The following is a description of a gene set: Genes predicted to be targets of miRBase v22 microRNA mmu_miR_7016_3p in miRDB v6.0 with MirTarget v4 prediction scores > 80 (high confidence targets). from publication Chen Y, Wang X (PMID 31504780) Mouse Gene Set: MIR_7016_3P species: Mus musculus, and this is the list of marker genes: Trappc12, Sgpp2, Kif26a, Zfp516, Pard3b, Polr1e, Gpr17, Syn3, Kcnk6, Nova2, Cacnb3, Ccdc22, Neo1, Gpr157, Zfp111, Sh3pxd2a, Nos1, Tpm4, Slc1a2, Nsd2, Pmvk, Parp14, Zdhhc1 (NCBI Gene Id 70796, zinc finger, DHHC domain containing 1), Pola2, Nit1, Slc30a9, Kcnc1, Clip2, Ccdc92b, Pum3, Zfp592, Sec14l3, Aida (axin interactor, dorsalization associated), Pex19, Galnt6, Fgf13, Lrig1 (NCBI Gene Id 232256), C2cd2l, Chrm1, Fbn1, Mgat3, Or12j5, Sema5a, Kdm3a, Tcam1, Bace2, Ptpro, Lingo2, C2cd2, Lsm11, Asxl2, Mesd, 0610030E20Rik, Kxd1, Lingo4, Ubxn7, Idh2, Zfp324, Fbf1, Sprn (shadow of prion protein), Bcl2l1, Pomt1, Dynll2, Amotl1, Gimap6, Scai, D130043K22Rik, Hsp90ab1